The following is a description of a gene set: Addition of multiple ubiquitin groups to a protein, forming a ubiquitin chain. Human Gene Set: GOBP_PROTEIN_POLYUBIQUITINATION studied in species Homo sapiens, and this is the list of marker genes: UBE2Q1, NOD2, NHLRC1, HAMP, ANAPC1, SASH1, DCAF15, AKTIP, RNF187, XIAP, SKP2, FZR1, RNF123, ZNRF1, NT5C2, KBTBD2 (kelch repeat and BTB domain containing 2), RUSC1, KCMF1, CUL3, BTRC, RNF185, UBE2B, UBE3A, ANAPC10, RNF41, WDR24, PEX12, MGRN1, STUB1, DTX4, RNF146, ANAPC16, RNF167, UBR5, UBE2H, SPOP, RNF7, RNF4, RNF34, UBE2D3, UBE2G2, MARCHF7, IRF2BP1, TRIM56, TNKS, RBCK1, CUL4B, PLAA (phospholipase A2 activating protein), MAGEL2, TRIM21, MDM2, ZNRF2, NHLRC3, GPS2, ANAPC15, UBE2Q2, TMEM129, FBXO22, TNFAIP3, CDC16, RNF183, NFE2L1, MARCHF6, TRAF2, WSB1, TRIM25, UBE2V2, UBE2V1, SYVN1, TRIM22 (tripartite motif containing 22), ANAPC4, BARD1, GABARAP, ZSWIM2, RIPK2, UBE2A, UBE2G1, RNF216, CDC27, FBXO4, KLHL20, DDB2, FBXO7 (F-box protein 7), PELI1, UBE3C, RNF115, PRKN, NQO1, UBE2E3, FBXL17, KLHL3, LNPEP, TTC36, PEX10, UBE2L5 (ubiquitin conjugating enzyme E2 L5), UBE2L6, TRAF6, SPSB4, BRCA1, UBE2U, BCL2, PELI3, UBE2D1, UBE2E2, UBE2L3, RNF126, RNF111 (NCBI Gene Id 54778), FBXO9, MYCBP2, MUL1, MKRN1, UBE2K, UBR4, SPSB3, UBE2J2, UBE2S, UBE2J1, DTL, UBOX5, ZNF738, RNF125, ANAPC13, NEDD4, NMI, KBTBD7, UBE2O, TRIM55, KBTBD6, ANAPC7, TRIM71, TRIM31, RNF20, RNF168, RNF39, RNF186, UBE2D2 (ubiquitin conjugating enzyme E2 D2), RNF144A, PPIL2, MKRN3, HACE1, ARIH2, THOP1, TRIM38, ANAPC11, RNF8 (ring finger protein 8), TRAF3IP2, ARK2C, TRIM2, BIRC2, TRIM26, TPP2, TRIM3, PARP10, UBE3B (ubiquitin protein ligase E3B), UBE2C, UBE4B, CBL (Cbl proto-oncogene), RFFL, SKP1, DAW1, MKRN2, BLMH, RNF166, CDC34, MARCHF5, ZNF598, PTPN22, TRIM65, RNF114, HUWE1, CUL5, ITCH, UBR2, DDA1, PELI2, NBN, HDAC6, RNF25 (NCBI Gene Id 79103), IFI27, SHARPIN, ARRDC4, RNF14, RNF135, TRAF7, FOXF2, WWP2, UBE2D4, UBE2W, TTC3, TRIM27, AMBRA1, RNF5, MARCHF1, DTX3L, TRIP12, SMURF1, WSB2, TOPORS, FBXO45, UBE2E1, AMFR, UBE2T, TRIM58, TRIM45, RNF31, CDKN2A, TRIM62, CTNNB1, TRIM5, CBFB, TRIM8 (tripartite motif containing 8), TAF1, TRIM44, ANAPC2, UBE2QL1, RBX1, NPEPPS, FBXO28, ERCC8, UBE2R2, C10orf90, RMND5A, AREL1, CEP63, MIR138-1, CDC26, RNF6, RNF180, CHFR, BFAR, RNF26, TRIM32, RNF213, RNF152, FBXW11 (F-box and WD repeat domain containing 11), WDR77, DZIP3, UBE4A, MARCHF8, RC3H2, UBE2NL, UBE2N, ASB11, DDX3X, TNKS2, ANAPC5, FBXL7, CDC23, SHPRH, TRIM6, TCF25, RC3H1, AXIN1 (axin 1), UBE3D, NEDD4L, LRSAM1, PRAME, CUL1, FBXO38, PPIA, RNF170, ZFP91, HECTD2, PRPF19, KLHL42